Given this list of marker genes TKT, RPIA, PGLS, TALDO1, G6PD, RPE, PGD, here is a description of the gene set: Human Gene Set: WP_PENTOSE_PHOSPHATE_METABOLISM Pentose phosphate metabolism studied in species Homo sapiens